The following is a description of a gene set: studied in species Mus musculus Mouse Gene Set: GOBP_PROTEIN_RETENTION_IN_ER_LUMEN The retention in the endoplasmic reticulum (ER) lumen of soluble resident proteins. Sorting receptors retrieve proteins with ER localization signals, such as KDEL and HDEL sequences or some transmembrane domains, that have escaped to the cis-Golgi network and return them to the ER. Abnormally folded proteins and unassembled subunits are also selectively retained in the ER., and this is the list of marker genes: Kdelr1, Ankrd13c, Kdelr2, Rer1, Os9, Grik5, Kdelr3